The following is a description of a gene set: species: Homo sapiens part of: Cellular responses to mechanical stimuli Reactome Pathway: Mechanical load activates signaling by PIEZO1 and integrins in osteocytes Osteocytes are mechanosensory cells in mineralized bone that have dendrites extending through lacunae (parallel with collagen fibers) and canaliculi (perpendicular to collagen fibers) to make contact with other osteocytes and with osteoblasts on the bone surface. Fluid flow and pressure in the lacunae and canaliculi are sensed by the dendrites and communicated to the cell body (inferred from mouse osteocytes in Burra et al. 2010), resulting in secretion of anabolic factors such as prostaglandin E2 (PGE2) that act to strengthen the bone.<br>Mechanosensitive PIEZO1 channels are opened by membrane stretch and transport calcium and sodium ions along their concentration gradients into the osteocyte. T-type voltage-sensitive calcium channels (CaV2 channles) open secondarily and augment the calcium influx. Cytosolic calcium activates Pannexin-1 (PANX1) channels, which transport ATP from the cytosol to the extracellular region. Extracellular ATP binds P2RX7 (P2X7) receptors located in a complex with PANX1. P2RX7 then transports cations including calcium into the cell and may act in an autocrine and paracrine manner to propagate waves of calcium influx.<br>Integrin alphaV:beta3 (ITGAV:ITGB3) located in the plasma membrane of dendrites binds the extracellular matrix of the lacunar or canicular wall. Fluid flow activates ITGAV:ITGB3 to phosphorylate AKT1 via a PI3K-dependent mechanism. Phospho-AKT1 then phosphorylates integrin alpha5 (ITGA5) and Connexin43 (GJA1) located in a complex in the plasma membrane of the cell body. Phospho-GJA1 transports ATP and PGE2 from the cytosol to the extracellular region.<br>CaV3.2 voltage-sensitive calcium channels also directly interact with the extracellular proteoglycan perlecan (PLN, PLC, HSPG2) and the alpha2delta1 subunit of the CaV3.2 complex (Reyes Fernandez et al. 2022). Physical force on perlecan may thus affect calcium transport by the CaV3.2 channels., and this is the list of marker genes: CACNB1, CACNA2D1, HSPG2, ITGB3, ITGB1, ITGA5, SPP1, CACNB3, P2RX7, CACNB2 (calcium voltage-gated channel auxiliary subunit beta 2), GJA1, PIEZO1, CACNA1H, PANX1, CACNG7, ITGAV, AKT1 (AKT serine/threonine kinase 1)